The following is a description of a gene set: studied in species Mus musculus This event has been computationally inferred from an event that has been demonstrated in another species.<p>The inference is based on the homology mapping from PANTHER. Briefly, reactions for which all involved PhysicalEntities (in input, output and catalyst) have a mapped orthologue/paralogue (for complexes at least 75% of components must have a mapping) are inferred to the other species. part of: Digestion and absorption electronically inferred by orthology from the curated human pathway Reactome Pathway: Intestinal absorption, and this is the list of marker genes: Slc2a5